Given this list of marker genes Inava, Rpl39, Coq8a, Sprr2g, Calcoco1, Cacybp, Sprr2h, Spc24, Selenot, Ccni, 1700123O20Rik (NCBI Gene Id 73643), Hmbox1, Ogfod2, Pla2g10, 6330403K07Rik, Smim8, Il1b (interleukin 1 beta), Tuba8, Jag1, Asns, Hspd1, Mrpl19, Ube4b, Sar1a, Slc39a13, Il36a, Rnf26, Vhl, Clec3b, Swap70, Zfp830, Tsc22d4, Prrc1, Myo1a, Pkhd1, Il17a, 1110004F10Rik, Serpinb3c, Bcl2a1d, Fam217a, Poli, Prss3b, Tlcd3b, 4930527J03Rik, Pdp2, Mt1, App, Stfa1, Tcte1, Ambra1, Zfp11, Otud1, Ythdf2, Armc9, Gclm, Nek4, 4933406D12Rik, Morn5, Siglece, Kprp, Pepd, Cspp1, 1700037C18Rik, Dguok, Cfap144, Lgmn, Gid8, Mapk8ip3, Pabpc4, Raph1, Galk1, Slc35b1, Dctn1, Ccl27a, Spanxn4, Rnf19a, Cenpc1, Best1, Kcnu1, Psg23, Bhlhe22, 2010203P06Rik, H2-M9, Txn1, Actl6b, Krtap5-4, Klk6, 4930511M18Rik (RIKEN cDNA 4930511M18 gene), Gstz1, Med17, Akr1c18, Pus10, Denr, Bid, Mycn, Rtn4r, Tyro3, Strap (NCBI Gene Id 97291), Ighg1, Sprr2k, Gtf2e2, Cds1, Fam162a (family with sequence similarity 162, member A), Acad9 (NCBI Gene Id 67022), Tex48, Srf, Cct6b, Fam186a, Lgals2, Eef1d, ENSMUSG00000122613, Tmem132cos, Calm2, Srsf1, Tnfrsf25, Cdc42ep2, Rpain, H2-Q5, Pmepa1, Cox19, Brf1, Ankef1, Sox5, Gtf2i, Ppp1r27, Sfpq (NCBI Gene Id 78315), 4930571K23Rik, Trem2, Tpm3, Chst11, Ptprjos1, Trpc6, Fbrsl1, Gadd45gip1, Abhd14b, Aff3, Scn1b, ENSMUSG00000136050, Arg1, Spata31d1e, Lmod2 (NCBI Gene Id 93677), Pex16, Wdr70, Apoe, Msi1, Rnase2b, Akirin2, Nbn, Meox2, Tmem144, Rptn, Qprt, Lyar, S100a11, Bmyc, Gdf5, Cx3cr1, Eif5a, Phf2, Pygo2, Pds5b, Nfe2l2, Chchd5, Col20a1 (NCBI Gene Id 73368), Tektip1, Pdxdc1 (pyridoxal-dependent decarboxylase domain containing 1), Ift20, Racgap1, Pacsin2, Samhd1, Spag5, Bag6, Trbv5, Ebf2, Rasip1, Krt2, Mef2c, Acta1 (NCBI Gene Id 11459), Itpr1, Brsk2 (BR serine/threonine kinase 2), Pvt1, Cp, Mgat1, Elapor1, 3110070M22Rik, Fam178b, Fes, Smim11, 4930556N13Rik, Hexa, Tssk6, 1700085D22Rik, Fam3a, Uck2, Zfp787, Camk4, 4930529K09Rik (RIKEN cDNA 4930529K09 gene), Sfn, Rspo1, Lrrc58, Hrc, Saraf, Nit1, Dok4, Rtraf, Ttc9, Calm4, Suclg2, Grip1, Krtap6-5, Gsta1, Anp32a, Dip2a, here is a description of the gene set: from publication Darwiche N, Ryscavage A, Perez-Lorenzo R, Wright L, Bae DS, Hennings H, Yuspa SH, Glick AB (PMID 17525749) Mouse Gene Set: DARWICHE_SKIN_TUMOR_PROMOTER_DN Chemical induction of squamous tumors in the mouse skin induces multiple benign papillomas: high-frequency terminally benign low-risk papillomas and low-frequency high-risk papillomas, the putative precursor lesions to squamous cell carcinoma (SCC). We have compared the gene expression profile of twenty different early low- and high-risk papillomas with normal skin and SCC. Unsupervised clustering of 514 differentially expressed genes (P<0.001) showed that 9/10 high-risk papillomas clustered with SCC, while 1/10 clustered with low-risk papillomas, and this correlated with keratin markers of tumor progression. Prediction analysis for microarrays (PAM) identified genes that distinguished the two papilloma classes, and a majority of these had a similar expression pattern in both high-risk papillomas and SCC. Additional classifier algorithms generated a gene list that correctly classified unknown benign tumors as low- or high-risk concordant with promotion protocol and keratin profiling. Reduced expression of immune function genes characterized the high-risk papillomas and SCC. Immunohistochemistry confirmed reduced T-cell number in high-risk papillomas, suggesting that reduced adaptive immunity defines papillomas that progress to SCC. These results demonstrate that murine premalignant lesions can be segregated into subgroups by gene expression patterns that correlate with risk for malignant conversion, and suggest a paradigm for generating diagnostic biomarkers for human premalignant lesions with unknown individual risk for malignant conversion. Genes down-regulated during skin tumor progression: epidermis treated with the carcinogen DMBA followed by 20 weekly applications of the tumor promoter TPA, compared to the untreated skin. species: Mus musculus